Given this list of marker genes TIMP2, TEAD1, EEF2K, RASSF3, FAM86C1P, NCL, DIDO1, MRPS16, KATNBL1, OPA3, FLT3LG, PPM1D, TET1, ATRN (NCBI Gene Id 8455), KLB, ERBB4, CHRNB2, BCAM, ALOXE3, EFR3B, B9D1, GOT2, SLAMF7, OST4, RBL2, CAPRIN1, RAP1GDS1, PCYOX1L (prenylcysteine oxidase 1 like), FAM131B, GLT1D1, CSDE1, PPP1R15B, NBEA, HAPLN1, FAM216B, HYCC2, ADGRL2, MPDU1-AS1, MAT2B, PBX1, MUC21, WDR7, MOGS, FZD3, ZCRB1, CSMD2, MAP4K5, WNT7B, ENO2, GSG1L, BCL6, TBL2, CHTOP, FAM86B1, GCH1, KRTAP5-11, SHISA6, TMED4, SMIM10L1, DCAF8, TRAPPC2L, MID2, TTC9, HSF2, GFAP, EEF2KMT, DIPK1A, HM13, EDNRB, GNG2, AMMECR1L, NLGN1, PPEF1, SIDT2, ERC1, ZNF609, COL2A1, C1QTNF3, CYP26B1, KRTAP5-10, NSD3, TMEM185B, SHCBP1, MMP25, KCTD4, DPH6, PTBP3, GRAMD1B, PCSK2, NUP98, TMEM230, SENP2, TLN2, FOXN1, SLC1A3, CLCA4, GPR158, KLHL4, COL5A1, NDRG4, USP49, HPS3, ALG8, CALCOCO1, ONECUT2, GLP1R, XPO1, LAMTOR1, here is a description of the gene set: from publication Chen Y, Wang X (PMID 31504780) species: Homo sapiens Human Gene Set: MIR5187_5P Genes predicted to be targets of miRBase v22 microRNA hsa-miR-5187-5p in miRDB v6.0 with MirTarget v4 prediction scores > 80 (high confidence targets).